Given this list of marker genes FBXL8, LINC01783, ZNF225, RNU4-74P, RNU1-141P, DEPDC7, ZC3H8 (zinc finger CCCH-type containing 8), CCDC7 (coiled-coil domain containing 7), CARF, NPPA, FAM156A, PER3, SESN2, FNDC8, RNU6-190P, RECK, MT-ND4, OR52H1, ID3, RPS29, MTMR11, ZNF181, POLR1HASP, CEP85, CATSPER2, MEPCE, ZNF429, BRD8, GLIDR, TMEM89, CES3, NCR2, PVRIG, TOB2P1, TMTC4, RCOR3, PDIK1L, MORN4, GMPPB, VN2R1P, SNURFL, ZNF738, PSRC1, RN7SL832P, MFSD9, CIART, ZNF30, TP53TG1, PPM1D, EPCAM, CCDC85C, CCNF, BTG2, DLEU2, TUBD1, RSRP1, ZNF354B, KIF18B, RNA5SP474, ZNF431, ZNF875, PLAG1, ZNF687, CEP43, LINC03006, SMG9, ARRDC3, PCLAF, BORA, ZSCAN22, BTNL3, TAS2R31, RNA5SP129, SNORA46, RPL21P53, RNU4-35P, ARMCX6 (armadillo repeat containing X-linked 6), DEPDC1 (NCBI Gene Id 55635), ZNF440, OR7E106P, IFRD1, ENSG00000290606, ZNF724, RPL31P28, SYNRG, RN7SL169P, KIF18A, CYTH2, DNMT3B, RN7SKP143, DCLRE1A, H2BC15, DIPK1C, FZD4, WNK1, SNORD59A, ZNF684, ZNF646, FAM217B, RAD52, CCDC150, NAP1L4, PIK3IP1, GPAM, SPATA33, C11orf54, MIR646HG, REV1, RN7SL468P, PDK4, ZNF510, STARD7-AS1, LIPT2-AS1, USP28, HINFP, ZNF37A, ENSG00000291065, OR1H1P, TP53INP1, DPH5, MTX3, CPEB3, LINC00487, SAXO4, GADD45G, FAM219B (family with sequence similarity 219 member B), UBE2H-DT, GAS6-AS1, TRIM51CP, SEM1, DCLRE1C, HDHD3, CSAD, ZNF564, TIGD1, RNY1P9 (RNY1 pseudogene 9), RASL11B, EAF2, PGAP1, LRRC37A, CENPL, TROAP, HMGB2, SLC26A7, ZNF678, XNDC1N, KRBOX4, SUV39H1, RBM4B, SNORA74C-1, GUSBP11, PNPLA3, RNPC3P1, RBM14, ZNF441, DPY19L2P2, LIMD1-AS1, MTRFR, GALNT16, H2BC2P, NDUFAF5, VAV3, ZNF833P, MTNAP1, MTND5P10, TET1, ZNF587, ZNF714, FAM43A, FCER1A, C6orf163, SLC5A12, ZNF79, STC2, FAM27E3, GAS5, LRIT1, PUM1, SEMA6D, PM20D1-AS1 (PM20D1 antisense RNA 1), TTC38, RNU6-1054P, SNORD7, AGAP4, PLEKHF2, DNAJB7, ARL4A, ZNF287, ZNF721, MKKS, RPL7L1P4, ZNF107, ZFP62, TRIM31, ZNF658, ZNF33A, PRSS37, ZNF767P, STAG3L4, FAM226B, FAM72C, FBXW7, ZNF302, LINC02210, SEPTIN7P13, DRD5, TIGD6, RNA5SP195, RN7SL513P, SAXO5, ZNF283, SNORA72, FIGN, PLIN4, ZNF493, EPM2AIP1, CTSK, ANKRD20A1, RNU4-89P, HYLS1, SENP8, ANKZF1, PEX11A, LYRM9, ZNF717, ARMC12, ZNF526, LRRC37B, NMRAL2P, WDR89, SLX4, JPX, CCDC136, H3C6, RNA5SP62, TSC22D3, ZNF792, F8, KCNQ4, CYP1A1, CYP2R1, BPIFA4P, SESN1, CDKN2C, GTF2IRD2, SLC38A11, ZNF732, RNA5SP151, HSD17B7 (NCBI Gene Id 63064), PIK3C2B, ADGRB3, H2BC7, ZNF470, UQCC1, DET1, VWDE, CDCA2, PPIL3, SPIN3, IFI44, GTSE1, ZNF630, VAMP1, TCEANC2, ASPA, FAM227A (family with sequence similarity 227 member A), ZNF280D, GOLGA2P10, H2BP1, BCRP8, BCL6, ZNF454, DNAJA1P5, LINC00174, INVS, LBHD1, ZNF483, ZNF780B, ZNF589, TRIM59, ZNF805, SKA1, GVQW3, RN7SL166P, LERFS (lncRNA negative regulator of fibroblast-like synoviocyte migration, SYNCRIP interacting), GAS2L3, E2F8, CDKN1B, FAM182A, ZBTB3, ANKRD36B, FLJ43315, ZNF138, ZBTB7B, OR5B3, POLH, ARL17A, PLEKHF1, RSPO2, PGF, H2AC17, HILPDA, PTPN20, HSP90B2P, ZNF740, NAPB, STAG3L1, SNORD116-19, KIF5A, ENSG00000238764, ZKSCAN5, ZNF117, OR2D3, CDCA8, ZNF436-AS1, OR7C2, RNU6-72P, OR2T34, POC5, DISP1, ENSG00000206987 (NCBI Gene Id 124900356), KCTD7, ALOX12P2, here is a description of the gene set: Normal cells require continuous exposure to growth factors in order to cross a restriction point and commit to cell-cycle progression. This can be replaced by two short, appropriately spaced pulses of growth factors, where the first pulse primes a process, which is completed by the second pulse, and enables restriction point crossing. Through integration of comprehensive proteomic and transcriptomic analyses of each pulse, we identified three processes that regulate restriction point crossing: (1) The first pulse induces essential metabolic enzymes and activates p53-dependent restraining processes. (2) The second pulse eliminates, via the PI3K/AKT pathway, the suppressive action of p53, as well as (3) sets an ERK-EGR1 threshold mechanism, which digitizes graded external signals into an all-or-none decision obligatory for S phase entry. Together, our findings uncover two gating mechanisms, which ensure that cells ignore fortuitous growth factors and undergo proliferation only in response to consistent mitogenic signals. from publication Zwang Y, Sas-Chen A, Drier Y, Shay T, Avraham R, Lauriola M, Shema E, Lidor-Nili E, Jacob-Hirsch J, Amariglio N, Lu Y, Mills GB, Rechavi G, Oren M, Domany E, Yarden Y (PMID 21596316) Human Gene Set: ZWANG_DOWN_BY_2ND_EGF_PULSE Genes down-regulated by second pulse of EGF in 184A1 cells (mammary epithelium). studied in species Homo sapiens